Given this list of marker genes ARRDC4, TRIM65, TRIM5, UBE2B (NCBI Gene Id 7320), NOD2, TRAF6, CDKN2A, RNF135, UBE2V2, GPS2, RNF5, RNF213, MARCHF5, PELI3, TRIM56, RNF4, RNF168, TRIM8, RNF126, TRIM22 (NCBI Gene Id 10346), TRIM3, RNF8, NEDD4, STUB1, UBE2O, TRAF3IP2, PRPF19, UBE2V1, KCMF1, UBE2E3, ITCH, UBE2S, ZFP91, RNF167, DDX3X, TRIM27, TRIM32, UBE2D4, RNF39, AKTIP, PLAA, ARIH2, UBE2E2, NBN, UBE2NL, UBE2G1, XIAP, RNF115, PELI1, UBE2N, TRIM21, RNF152 (ring finger protein 152), BFAR (NCBI Gene Id 51283), PTPN22, TRAF2, UBE2T, RIPK2, PRKN, MAGEL2, UBR2, RNF186, CEP63, MIR138-1, SASH1, ZNF598, SKP2, WWP2, TRIM31, BIRC2 (baculoviral IAP repeat containing 2), PARP10, here is a description of the gene set: Human Gene Set: GOBP_PROTEIN_K63_LINKED_UBIQUITINATION A protein ubiquitination process in which a polymer of ubiquitin, formed by linkages between lysine residues at position 63 of the ubiquitin monomers, is added to a protein. K63-linked ubiquitination does not target the substrate protein for degradation, but is involved in several pathways, notably as a signal to promote error-free DNA postreplication repair. studied in species Homo sapiens